Given this list of marker genes OPN4, OPN1LW, RGR, OPN1MW, OPN1SW (opsin 1, short wave sensitive), RHO, OPN3, RRH, OPN5, here is a description of the gene set: species: Homo sapiens Human Gene Set: REACTOME_OPSINS Opsins